The following is a description of a gene set: Mouse Gene Set: MIR_485_3P from publication Chen Y, Wang X (PMID 31504780) species: Mus musculus Genes predicted to be targets of miRBase v22 microRNA mmu_miR_485_3p in miRDB v6.0 with MirTarget v4 prediction scores > 80 (high confidence targets)., and this is the list of marker genes: Atrx, Ccl7 (C-C motif chemokine ligand 7), Htr4, Tmem106b, Cep57l1, Zbtb43, Jade1, Ibtk, Gimap5, Slc40a1, Ckmt2, Ptpmt1, Mier3, Cmtr2, Slc35a1, Zbtb41, Il1rl1, Igf2bp3, Mtmr2, Slc12a7, Slc25a36 (solute carrier family 25, member 36), Cyp20a1, Nwd2, Arhgef15, Pde10a, Cnot2, Ophn1, Trim60, Tex11, Oasl2, Upf3b, Mindy2, Trdmt1, Psip1, H2-M10.1, Slc45a2, Zcchc2, 1700013H16Rik, Rnf182, Kif27, Adnp, 1700028K03Rik, Tent2